Given this list of marker genes Scrib, Atxn2, Prkca, Wdr54, Vtn, Arap1, Hpca, Drd4, Wasl, Il4, Tspan7, Dgkd (NCBI Gene Id 98439, diacylglycerol kinase, delta), Trf, C3, Flot1, Syt17, Cbl (Casitas B-lineage lymphoma), Wnt3a, B2m, Rala, Sfrp4, Plcg2, Ncdn, Hap1, Efnb2, Rabgef1, Ophn1, Arc, Dnm2, Bicd1, Necab2, Apoc1, Dab2, Ppt1, Vegfa, Hamp2, Ankrd13d, Numb, App, Napb, Sh3gl3, Picalm, Apoc2l, Snap91, Arrb1, Rnf220, Neu3, Ccr7, Itgav (integrin alpha V), Atad1, Synj2bp, Pick1 (protein interacting with C kinase 1), Ccdc32, Ap2a1, Dnajc6, Dkk1, Mtmr2, Dlg4, Rin3, Kif3a, Synj1, Apoc3, Tbc1d5, Iqsec1, Ntf3, Lrp1, Lrpap1, Anxa2, Syt11, Ccl19, Cblb, Rnf216, Fmr1, Bmp2k, Nsf, Rspo1, Sele, Lrrtm1, Dtnbp1, Arrb2, Sgip1, Unc119, Pcsk9, Ubqln2, Grem1, Ankrd13a (ankyrin repeat domain 13a), Adipoq, Hip1, Arf1, Pip5k1c, Susd4, Hnrnpk (NCBI Gene Id 15387), Ppp3r1, Aplnr, Ldlrap1, Nedd4 (neural precursor cell expressed, developmentally down-regulated 4), Cd63, Usp46, Smap1, Ccl21a, Hfe, Pld2, Lpar1, Apoc2, Hamp, Itgb3, Drd2, Ap2m1, Tnk2, Ankrd13b, Cd2ap, Nrg1, Rabep1, Aak1, H1f1, Apln, Apela, Abca2, Ush1g, Vac14, Hip1r, Nedd4l, Pard3, Ahi1, Gsg1l, Pacsin1, Serpine1, Magi2, Tamalin, Akap5 (A kinase anchor protein 5), Lrrtm2, Syk, Sh3gl2, Clu, Plk2, Mdm2, Sdcbp, Insr, Drd3, Egf, Ptpn5, Angpt1, Sirt2, Rab21, Mkln1, here is a description of the gene set: Any process that modulates the frequency, rate or extent of receptor mediated endocytosis, the uptake of external materials by cells, utilizing receptors to ensure specificity of transport. Mouse Gene Set: GOBP_REGULATION_OF_RECEPTOR_MEDIATED_ENDOCYTOSIS studied in species Mus musculus